Given this list of marker genes Nlrc3, Pik3r2, Pik3r1 (phosphoinositide-3-kinase regulatory subunit 1), Xbp1, Cbl, Fam83b, Esr1, Ptpn13, Cd2ap, Fam83a, Fbxl2, Dnm2, Pik3ap1, Dab2ip, here is a description of the gene set: studied in species Mus musculus Mouse Gene Set: GOMF_PHOSPHATIDYLINOSITOL_3_KINASE_REGULATORY_SUBUNIT_BINDING Binding to a regulatory subunit of phosphatidylinositol 3-kinase. The regulatory subunit associates with the catalytic subunit to regulate both its activity and subcellular location.